Given this list of marker genes CARHSP1, TMEM185A, PIERCE1, PMM1 (NCBI Gene Id 5372), H2AJ, TXNIP, CDKN1A, ABLIM1, ADGRE1 (NCBI Gene Id 2015), TRAFD1, NECTIN4, VMP1, EI24, TP53INP1, CD53, ZFP36L1, MDM2, LPIN1, LRRC2, MALAT1, CCNG1, TOB1, BTG2, here is a description of the gene set: from publication Brachat A, Pierrat B, Xynos A, Brecht K, Simonen M, Brüngger A, Heim J (PMID 12447701) DNA microarrays are powerful tools for the analysis of gene expression on a genomic scale. The importance of individual regulatory events for the process under study can however not be deduced unequivocally without additional experiments. We devised a strategy to identify central regulators of cancer drug responses by combining the results of microarray experiments with efficient methods for phenotypic testing of candidate genes. We exposed murine FL5.12 pro-B cells to cisplatin, camptothecin, methotrexate or paclitaxel, respectively and analysed the patterns of gene expression with cDNA microarrays. Drug-specific regulatory events as well as intersections between different apoptotic pathways, including previously studied responses to staurosporine and interleukin-3 (IL-3) deprivation, were identified. Genes shared by at least three pathways were chosen for further analysis. Ectopic expression of three such genes, TEAP, GP49B, and Lipin1 was found to have an anti-proliferative effect on pro-B cells. Interestingly, we identified hemoglobin alpha as a strong pro-apoptotic regulator. While hemoglobin-expressing cells were growing normally in the presence of IL-3, they displayed accelerated apoptosis with similar kinetics as Bax overexpressing cells upon IL-3 removal. The pro-apoptotic effect of hemoglobin was suppressed by Bcl-2 and was characterized by enhanced stimulation of caspase activity. Genes up-regulated in FL5.12 cells (pro-B lymphocyte) in response to methotrexate. studied in species Mus musculus Human Gene Set: BRACHAT_RESPONSE_TO_METHOTREXATE_UP